The following is a description of a gene set: studied in species Mus musculus Mouse Gene Set: GOCC_PROTON_TRANSPORTING_TWO_SECTOR_ATPASE_COMPLEX_PROTON_TRANSPORTING_DOMAIN A protein complex that forms part of a proton-transporting two-sector ATPase complex and carries out proton transport across a membrane. The proton-transporting domain (F0, V0, or A0) includes integral and peripheral membrane proteins., and this is the list of marker genes: Atp6v0a4, Atp6v0d1 (NCBI Gene Id 11972), Rnasek, Atp6v0a1, Atp6v0e2, Atp6v0d2, Atp6v0c, Atp6v0a2, Atp6v0e, Atp6v0b, Atp6ap2